Given this list of marker genes PLXNA1, CD72, PLXNA2, PLXNA4, SEMA4D, TYROBP, PLXNC1, PLXNB3, SEMA6D, SEMA4A, SEMA7A, TREM2, SEMA3E, SEMA5A, ITGA1, ITGB1, PTPRC, PLXND1, SEMA6A, here is a description of the gene set: studied in species Homo sapiens Other semaphorin interactions Human Gene Set: REACTOME_OTHER_SEMAPHORIN_INTERACTIONS